The following is a description of a gene set: The directed movement of an alkanesulfonate into, out of or within a cell, or between cells, by means of some agent such as a transporter or pore. Alkanesulfonates are organic esters or salts of sulfonic acid containing an aliphatic hydrocarbon radical. species: Mus musculus Mouse Gene Set: GOBP_ALKANESULFONATE_TRANSMEMBRANE_TRANSPORT, and this is the list of marker genes: Slc16a6, Lrrc8c, Lrrc8d, Slc6a13, Slc6a6, Lrrc8a, Slc6a11, Slc36a1